Given this list of marker genes Atp7a, Mmgt2, Slc31a1, Hephl1, Mmgt1, Steap1, Steap4, Slc46a3 (NCBI Gene Id 71706), Steap3, Atox1, Steap2, Slc39a11, Slc31a2, Atp7b, Fkbp4, Slc11a2, here is a description of the gene set: The directed movement of copper (Cu) ions into, out of or within a cell, or between cells, by means of some agent such as a transporter or pore. Mouse Gene Set: GOBP_COPPER_ION_TRANSPORT species: Mus musculus